Given this list of marker genes RNF103, AMFR, RNF5, MAN1B1, MARCHF6, SYVN1, UGGT2, EDEM2, UGGT1, TRIM13, UBA52, DERL2, RNF185, EDEM3, SEL1L, UBC, OS9, UBB, RPS27A, RNF139, EDEM1, here is a description of the gene set: Human Gene Set: REACTOME_ER_QUALITY_CONTROL_COMPARTMENT_ERQC studied in species Homo sapiens ER Quality Control Compartment (ERQC)